The following is a description of a gene set: Transcription regulation during the cell cycle is crucial for ensuring genes are expressed at the right time and in the correct amounts, coordinating key processes like DNA replication, mitosis, and cell division. In our study, Genes whose expression fluctuates during the cell cycle (pVal < 0.05) and peaks in early M (M) in K562 Human Gene Set: PULVER_FOREY_CELLCYCLE_PEAKING_M species: Homo sapiens, and this is the list of marker genes: NUTM2B, TRIM69, P2RY11, RAPGEF2, NBPF1, ZNF641, TRAF3IP2, NUDT19, ZNF561, GBE1, ABCB1, PACS2, ZNHIT1, TXK, PRAME, USP35, LRRC27, LMNA, THEMIS2, MGRN1, PACS1 (phosphofurin acidic cluster sorting protein 1), ARHGAP27, UAP1L1, MAP3K3, BAIAP2, EDEM2, TBC1D9B, ATXN7L3B, RPS6KC1, VIPAS39, NPAS1, MAP4, MXRA8, ZFYVE28, PYCARD, BBOF1, AAMDC, IL17RE (interleukin 17 receptor E), TMEM187, KALRN, KLC3, UBALD1, SYS1, PPP2R5B, PCED1B, FOXO4, LIME1, PRX, CAVIN1, HAS1, FBXO44, LIMA1, SMYD3, SGK1, ABHD17A, SGSH, SIN3B, PSMF1, CEP104 (centrosomal protein 104), RAPGEF3, CAPN12, EGR3, ZNF319, PLPPR3, LNP1, IP6K2, CAMK2G, NHERF2, UBTD1, LZTS2, KCNJ14, PPM1F (NCBI Gene Id 9647), CBFA2T2, LIFR, GIPC1, FOS, TMEM41A, DNAJB6, BTN3A2, SIAE, SMOX, HPCAL1, TMEM150A, KIT, CLSTN3, EIF2B4, JUP, ARRB1, TMEM63B, NIPSNAP1, RTN2, GCC1, TAMALIN, GAS2L1, CARM1, BABAM1, TULP4, F12, USP38, TMEM63A, PIK3IP1, NFS1, PORCN, MOB3C, SLC12A9, EPN2, GPR107, DBP, KDM7A, APBA2, SALL2, DRG2, NELFA (NCBI Gene Id 7469), CDK7, WDR81, TENT5B, RNF207, UBASH3A, TJP3, ORAI2, TBKBP1, SHROOM1, CLIC1, ZXDB, CLEC11A, CAMKK1, EXD2, SSH1, FMNL1, RITA1, SSU72, ZNF550, HOXB3, PTTG1, MYD88 (NCBI Gene Id 4615), TAGLN, RNF149, GTF2E1, PDGFA, ANXA4 (NCBI Gene Id 307), CFAP36, MVB12A, RABEPK, EVI5, RETSAT, EFNA1, ADAMTSL5 (ADAMTS like 5), NTHL1, IL27RA, MAP2K5, NOL3, AMHR2, ANKRD62 (NCBI Gene Id 342850), QPRT, ZKSCAN3, GYS1, ZNF304, COL9A2, PLEKHA4, MICALL2, MAP1A, ZNF559, HSD3B7 (NCBI Gene Id 80270), CYB561, TMEM164, PIK3CG, LAMB2, SLC27A1, GHDC, SHISA5, FHIP2B, BAK1, ZNF266, GTF2E2, ZNF426, POMT1, TMEM43, HDHD3, DPCD, RAPGEFL1, CASKIN1, ZNF579, YKT6, STX16, PHLDB1, DGKA, CIB1, CCS, ZNF571, ZSCAN32, PELO (NCBI Gene Id 53918), SAT2, GCNT2, SH3BP5 (NCBI Gene Id 9467), ZDHHC9, MFSD4B (major facilitator superfamily domain containing 4B), RTKN, SLC16A3, CAPN2, SPI1, TNK1, MRAP2, RYR1, RHOB, ERMARD, MEF2D, ZBTB46, KCNN4, RAB29, SNAI1, MTMR14, DLG4, CACNB1, CDPF1, IQCE, AHNAK, TPRN, AMPD2, OS9, LBHD1, COG7, WASHC2C, SH3PXD2A, ABTB2, GALNS, PRDM15, ZNF169, BATF2 (NCBI Gene Id 116071), ZNF669, CD44, OPRL1, MARCHF8, WDR90, NLGN2, SIPA1L3, TMEM127, SNAPC4, POMGNT1, CREB3L1, PLIN3, MFSD10, ZNF275, STYXL1, NUBPL, STAT2, TGM2, BCL9L, SDC3, GRINA, PDCD6, DAPK1, TNIP2 (TNFAIP3 interacting protein 2), SAMD10, IDUA, PI4K2A, GFOD2, LMOD1 (NCBI Gene Id 25802), CERCAM (NCBI Gene Id 51148), EHMT2 (NCBI Gene Id 80735), ACAA1, USP40, ANXA1, LRRC56, THAP3, TAF12, PDLIM4, PEX6, SLC9A5, NIBAN2, POLR1H, RILPL2, ARHGAP25, ATRN, RAC2, RAB11FIP3, ZFP41 (ZFP41 zinc finger protein), ZNF496, NCF2, DPH5, B3GNT2, VCL, FADS3, ORMDL3, CDC20, CDKN3, CLBA1, XKR8, MYRF, CYTH4 (cytohesin 4), PLEKHH1, APC2, SPATA2L, SPA17, MOSPD3, CCDC116 (NCBI Gene Id 164592), STX6, FN1, ZNF160, ARID4B, AFG2B, PTPRJ, MPZL1, PREB, PRMT2, MC1R, CRTC2, STX18, SEMA4G, MMP19, ZKSCAN8, RGS19, DRD2, TRIM3, ZFP92, PRR7, FAM78B, SRC, CEMIP2, FCGR2B, LRG1, ERN1 (endoplasmic reticulum to nucleus signaling 1), WFIKKN1, SIRT2, LRFN1, RASIP1, TMEM217, DDAH2, PRKCA, TRAPPC3, KCNN3, POLM, TUBA1A, DNAAF9, AKR1C3, PRRT1, CYBRD1, HLA-E, MCRIP1, NPEPPS, ZDHHC24, MKRN1, THBS3, MARK4, ZNF728, TLE6, UQCRFS1, PLEKHB2, PYURF, ATP6V1B2, MBTPS1, DOK2, ANKRD13D, SUSD2 (sushi domain containing 2), DNASE1 (deoxyribonuclease 1), GRB2, BTBD2, FAM220A, COMT, PXN (paxillin), TESK2, GBGT1, GPRC5C, STXBP2, DLX2, ALAD, CHKA, SGSM2, SMAGP, LRSAM1, FAAH, C3orf18, NCKAP1L, ZNF416, PRF1, MEAK7, DNAJC18, ZNF382, UTF1, DAGLB, GIT1, ERBB3, MXD4, ZNFX1, SLC25A38, GSPT2, CDC42BPB, ZNF74, MTFR1L, QPCTL, FNDC3B, PIK3CD, KRT19, RABEP2, NAA30, AAK1, CMTM3, TRAFD1 (TRAF-type zinc finger domain containing 1), TEP1, CDK5, ERGIC1, NCDN, MOK, DIPK1B, ZNF805, TMEM134, PLTP, LAMTOR2, GAS8, MED18, RAB3IL1, C1orf167, MAP7D1, XIRP1, CRELD1, ARHGEF6, ROBO2 (roundabout guidance receptor 2), RALGDS, PTPA, ALPK1, OSGEPL1, MYEF2, ZFP64, LACTB, ZNF701, RTL10, GPKOW, EGF, LRFN4, METTL8, ZNF512B, WDR59, ZNF586, ZNF134, LASP1, RASGEF1A, TNK2, C1orf174, PAQR7, KCTD13, MNT, DOCK6, VAV1, IRGQ, QRICH2, PLEKHO2, ANKRD52, HEXIM1, COL15A1, ARMC7, NDUFA10, ZNF358, DLK1, NT5DC4, WDR37, PLPP7, ICAM1, HYOU1, IFI6, KCNE3, TRPV2, TOB2, HYAL1, FTCD, SUPT5H, GNB1L, MLF2, P2RX1, MINDY1, CRAT, KCTD11, S100A13, PRR11, GORASP1, AMH, CPNE1, STAT6, CDK8, FLYWCH2, MARCHF2, DEF6, SMAD3, PBXIP1, EPAS1, TUBB2A, STING1, VIM, RGS9BP, CBARP, MAPKBP1, HMOX2, PWWP2B, SLC25A43, ZNF174, NEIL2, CTSS, EML2, DBN1, TMT1A, CCDC32, PTHLH, LRIT3, KCTD21, HDC, FNBP1, KLHL18, LGALS1 (galectin 1), PLAU, TBC1D13, PRSS57, ANKRD16, TNNI3, PPP1R3B, ARHGAP39, ITPKB, ATF7-NPFF, ABCC10, ZFAND3, ZFP82, NRBP1, ENTREP3, CSF1, SIDT2, SDF2L1, LCA5L, MED10, MAST3, ARL8A, SLC39A14, THRA, FBXL19, ZNF317, CUL7, SLC35C1, SLC41A1, USH1G, HEPH, TLE2, JADE2, TRMU, BCORL1, RARG, DLGAP4, ACSM3, IRAK2, RARA